Given this list of marker genes Abca2, Apoa1, Lamtor1, Ces1a, Abca8a, Cav1, Eepd1, Lrp1, Pon1, Shh (sonic hedgehog), Ces1f, Zdhhc8, Ces1c, Naxe, Abca3, Ces1e, Ces1b, Nfkb1, Nr1h2, Srebf2, Ptch1, Apoe, Ttc39d, Abca12, Abca7, Abca5, Trem2, Abcg4, Ces1h, Ces1g, Egf, Ttc39b, Gps2, Abca8b, Sirt1, Yjefn3, Pla2g10, Pparg, Abca1, Adipoq, Ces1d, Nr1h3, Nfkbia, Irak1, Abcg1, Pltp, here is a description of the gene set: studied in species Mus musculus Any process that modulates the frequency, rate or extent of cholesterol efflux. Cholesterol efflux is the directed movement of cholesterol, cholest-5-en-3-beta-ol, out of a cell or organelle. Mouse Gene Set: GOBP_REGULATION_OF_CHOLESTEROL_EFFLUX